Given this list of marker genes MAP2K3, MATK, CYB561D2, PRSS23, ATG2A, PROCR, IFNG, YARS1, PTGDR (prostaglandin D2 receptor), CST7, KLRD1, KLRA1P, POP4, CALR, HOMER1, RHOF, MT1E, RIC8A, PPP3CA, FCGBP, KLRF1, RFTN1, F2R, APMAP, CHSY1, CACNA2D2, DNAJC1, AOAH, SYT11, PTPN4, ABCA2, SH2D2A, SRPK2, GTF3C1, KLF10, BRAP (NCBI Gene Id 8315), SMAD7, ID2, CHI3L2, PIGT, VCAM1, JMJD6, PRF1, ITGAL (integrin subunit alpha L), MAFF, ADRB2, IDS, GTDC1, RMND5A, RAB5C, PLOD1, IL2RB, LITAF, LLGL2, MYBL1, CD8B, VPS37B, ENC1, JAKMIP2, ZFTA, PIN1, TGFBR3, CRIM1, FASLG, POMP, CCL5, CHP1, RGS3, EMD, FKBP11, DPY19L1, ARPC5L, NAA50, XPNPEP1, GPR137B, MAP3K8, SRSF9, ATP1B3, APOBEC3G, PDSS2, ADAP1, EIF4G3, PTS, SCCPDH, LAG3, CBLB, PLAAT3, SLC36A1, CAMK2N1, C11orf21, BZW1, KLRK1, GALNT11, TSPOAP1, SRRT, YWHAQ, SLC27A3, GZMB, KLRG1, HOXC4, IPPK, CX3CR1, PPM1A, ACAA2, H4C11, PIP4K2A, DUSP2, UAP1, PITPNC1, TTC38, CYRIB, MFSD10, BPGM (NCBI Gene Id 669), NCALD (NCBI Gene Id 93992), G6PD, KLRC3, GSE1, MT1F, IQGAP1, CLIC3, PARP8, H2AX, SH2D1A, PTCH1, HOPX, ATP8A1, FABP5, CRTAM, GZMA, RAP2A, KLRC4, WIPI1, RBBP7, CHST12, PECAM1, ANTKMT, LSM1, GZMH, PDZD8, AGAP1, PRPF31, HEXIM1, ARHGAP26, PLEK, CD8A, STK17A, TARP, CCL4, TXNL4A, EFHD2, ADIPOR2, PHGDH, ADGRG1, RAB5IF, MFN2, SAR1A, GATA6, CD248, C1orf21, RAB27A, TBX21, MXRA7, CTSW, SLAMF7, NPC1, RAB29, PRR5L, NCR3, TSPAN32, CARS1, TBKBP1, RHBDF2, CD244, ITPK1, CD63, E2F3, RALGDS, MT2A, MVB12B, YBX3, GATAD2A, ZNF184, ZEB2, XCL1, SEPTIN11, UBB, SLC25A4, NT5E, LYST, TIPARP, GZMK, MANF (mesencephalic astrocyte derived neurotrophic factor), ABCB1, TPST2, GGA1, RUNX3, NKG7, CD160 (NCBI Gene Id 11126), YES1, F8, here is a description of the gene set: It has been recently shown that N-ras plays a preferential role in immune cell development and function; specifically: N-ras, but not H-ras or K-ras, could be activated at and signal from the Golgi membrane of immune cells following a low level TCR stimulus. The goal of our studies was to test the hypothesis that N-ras and H-ras played distinct roles in immune cells at the level of the transcriptome. First, we showed via mRNA expression profiling that there were over four hundred genes that were uniquely differentially regulated either by N-ras or H-ras, which provided strong evidence in favor of the hypothesis that N-ras and H-ras have distinct functions in immune cells. We next characterized the genes that were differentially regulated by N-ras in T cells following a low-level TCR stimulus. Of the large pool of candidate genes that were differentially regulated by N-ras downstream of TCR ligation, four genes were verified in qRT-PCR-based validation experiments as being differentially regulated by N-ras (Dntt, Slc9a6, Chst1, and Lars2). Finally, although there was little overlap between individual genes that were regulated by N-ras in unstimulated thymocytes and stimulated CD4+ T-cells, there was a nearly complete correspondence between the signaling pathways that were regulated by N-ras in these two immune cell types. Since we were interested primarily in genes that were differentially regulated by N-ras following a low-level TCR stimulus, our microarray data comparison was between data from TCR-stimulated, WT CD4+ T-cells and from TCR-stimulated, N-ras KO CD4+ T-cells. Genes that were differentially regulated in the comparison between stimulated N-ras KO CD4+ T-cells and unstimulated N-ras KO CD4+ T-cells, as well as those genes that were differentially regulated in the comparison between stimulated WT CD4+ T-cells and unstimulated WT CD4+ T-cells were excluded from this analysis. To determine if N-ras and H-ras regulate different sets of genes in thymocytes, a comparison was made between the set of genes that were differentially regulated by N-ras in the vs. comparison and the set of genes that were differentially regulated by H-ras in the vs. comparison. Human Gene Set: GSE45739_UNSTIM_VS_ACD3_ACD28_STIM_WT_CD4_TCELL_DN Genes down-regulated in CD4 T cells: unstimulated versus activated. species: Homo sapiens from publication Lynch SJ, Zavadil J, Pellicer A (PMID 23755101)